Given this list of marker genes PCCA, MMAA, MMUT, PCCB, MCEE, here is a description of the gene set: part of: Mitochondrial Fatty Acid Beta-Oxidation species: Homo sapiens Reactome Pathway: Propionyl-CoA catabolism Propionyl-CoA is a product of the catabolism of the amino acids, leucine, methionine, and threonine, and of the beta-oxidation of fatty acids with odd numbers of carbon atoms. The three reactions of this pathway convert propionyl-CoA to succinyl-CoA, an intermediate of the citric acid cycle. Through these reactions, carbon atoms from these sources can be fully oxidized to produce energy, or can be directed to gluconeogenesis. The three reactions of propionyl-CoA catabolism take place in the mitochondrial matrix.